The following is a description of a gene set: Human Gene Set: MIR10396A_3P_MIR10396B_3P Genes predicted to be targets of miRBase v22 microRNA hsa-miR-10396a-3p, hsa-miR-10396b-3p in miRDB v6.0 with MirTarget v4 prediction scores > 80 (high confidence targets). from publication Chen Y, Wang X (PMID 31504780) studied in species Homo sapiens, and this is the list of marker genes: TAFA3, CERS1 (ceramide synthase 1), YPEL2, ZNF319, CLOCK